The following is a description of a gene set: part of: Cellular response to starvation species: Homo sapiens Reactome Pathway: Amino acids regulate mTORC1 The mTORC1 complex acts as an integrator that regulates translation, lipid synthesis, autophagy, and cell growth in response to multiple inputs, notably glucose, oxygen, amino acids, and growth factors such as insulin.<br>MTOR, the kinase subunit of mTORC1, is activated by interaction with RHEB:GTP at the cytosolic face of lysosomal membrane. Recruitment of mTORC1 to the lysosomal membrane is intricate and incompletely understood. At the center of the system is a complex of two small GTPases, the Rag heterodimer (RRAGA or RRAGB bound to RRAGC or RRAGD). The Rag heterodimer is tethered to the membrane by the Ragulator complex, which also binds the v-ATPase complex. The Rag heterodimer acts as a cross-regulating switch, with the binding of GTP by one subunit inhibiting the exchange of GDP for GTP by the other subunit. The active conformation of the Rag heterodimer that recruits mTORC1 to the lysosomal membrane is RRAGA,B:GTP:RRAGC,D:GDP while the inactive conformation, RRAGA,B:GDP:RRAGC,D:GTP, releases mTORC1. GTPase activating proteins (GAPs) and guanyl nucleotide exchange factors (GEFs) acting upon the Rag heterodimer thereby regulate recruitment of mTORC1. RHEB:GTP at the lysosomal membrane also binds mTORC1 and directly activates mTORC1. During inactivation of mTORC1 in response to removal of amino acids, the TSC complex, a GAP for RHEB, is required in addition to the inactive Rag complex to release mTORC1 from RHEB and hence fully release mTORC1 from the lysosomal membrane.<br>Amino acids regulate recruitment of mTORC1 to the lysosomal membrane by at least 4 mechanisms. 1) Sestrin1 (SESN1) or Sestrin2 (SESN2) binds leucine and the Sestrin1,2:leucine complex is then released from the GATOR2 complex, allowing GATOR2 to positively regulate mTORC1 activation. 2) CASTOR1 in a homodimer or a heterodimer with CASTOR2 binds arginine and the CASTOR1:arginine complex is likewise released from GATOR2, allowing GATOR2 to activate mTORC1. 3) BMT2 (SAMTOR), a negative regulator of mTORC1 activation, binds S-adenosylmethionine (SAM), a derivative of methionine. The binding of SAM causes BMT2 to dissociate from GATOR1, allowing the activation of mTORC1. 4) The amino acid transporter SLC38A9 binds arginine and SLC38A9 then acts as a GEF to convert RRAGA,B:GDP to the active form, RRAGA,B:GTP. Amino acid starvation also regulates the assembly of the V0 and V1 subunits of v-ATPase by an uncharacterized mechanism and v-ATPase is required for activation of mTORC1 by amino acids. Glutamine activates mTORC1 by a mechanism that is independent of the Rag GTPases, requires ARF1, but is not yet fully elucidated., and this is the list of marker genes: DEPDC5, ATP6V1A, ATP6V1E2, SEC13, CASTOR1, SESN2, RPTOR, ATP6V1D, ATP6V0D1, SESN1, ATP6V1G1, RRAGB, RRAGC, KICS2, LAMTOR1, ATP6V1B1, NPRL2, ATP6V0E2, ATP6V0D2, ATP6V0B, ITFG2, TCIRG1, SAMTOR, RRAGD, CASTOR2, SH3BP4, ATP6V0E1, FLCN, RRAGA, WDR24, ATP6V1G2, LAMTOR3, ATP6V1B2, FNIP2, ATP6V1G3, MTOR, MLST8, LAMTOR4, ATP6V1C2, ATP6V1F, ATP6V1C1, KPTN, ATP6V1H, LAMTOR5, SZT2, RHEB, ATP6V0C, WDR59, FNIP1, SLC38A9, ATP6V1E1, MIOS, SEH1L, NPRL3, LAMTOR2